The following is a description of a gene set: Any process that decreases the frequency, rate or extent of the directed movement of sodium ions (Na+) into, out of or within a cell, or between cells, by means of some agent such as a transporter or pore. Mouse Gene Set: GOBP_NEGATIVE_REGULATION_OF_SODIUM_ION_TRANSPORT species: Mus musculus, and this is the list of marker genes: Stk39, Nedd4, Camk2d, Wnk4, Osr1, Serpine2, Nherf1, Agrn, Wnk2 (NCBI Gene Id 75607), Pcsk9, Commd1, Grp, Wnk3 (NCBI Gene Id 546388), Wnk1, Nedd4l